The following is a description of a gene set: from publication Korkola JE, Houldsworth J, Chadalavada RS, Olshen AB, Dobrzynski D, Reuter VE, Bosl GJ, Chaganti RS (PMID 16424014) Human Gene Set: KORKOLA_SEMINOMA_UP Genes from the 12p region that were up-regulated in seminoma tumors compared to normal testis. studied in species Homo sapiens Adult male germ cell tumors (GCTs) comprise distinct groups: seminomas and nonseminomas, which include pluripotent embryonal carcinomas as well as other histologic subtypes exhibiting various stages of differentiation. Almost all GCTs show 12p gain, but the target genes have not been clearly defined. To identify 12p target genes, we examined Affymetrix (Santa Clara, CA) U133A+B microarray ( approximately 83% coverage of 12p genes) expression profiles of 17 seminomas, 84 nonseminoma GCTs, and 5 normal testis samples. Seventy-three genes on 12p were significantly overexpressed, including GLUT3 and REA (overexpressed in all GCTs) and CCND2 and FLJ22028 (overexpressed in all GCTs, except choriocarcinomas). We characterized a 200-kb gene cluster at 12p13.31 that exhibited coordinated overexpression in embryonal carcinomas and seminomas, which included the known stem cell genes NANOG, STELLA, and GDF3 and two previously uncharacterized genes. A search for other coordinately regulated genomic clusters of stem cell genes did not reveal any genomic regions similar to that at 12p13.31. Comparison of embryonal carcinoma with seminomas revealed relative overexpression of several stem cell-associated genes in embryonal carcinoma, including several core stemness genes (EBAF, TDGF1, and SOX2) and several downstream targets of WNT, NODAL, and FGF signaling (FGF4, NODAL, and ZFP42). Our results indicate that 12p gain is a functionally relevant change leading to activation of proliferation and reestablishment/maintenance of stem cell function through activation of key stem cell genes. Furthermore, the differential expression of core stem cell genes may explain the differences in pluripotency between embryonal carcinomas and seminomas., and this is the list of marker genes: AK4 (NCBI Gene Id 387851), GABARAPL1, RECQL, CD27, NOP2, KLRG1, DSTNP2, PHC1, DERA, COPS7A, ITFG2, PHB2, SINHCAF, SLC2A3, TIGAR, GAPDH, LRP6, TEAD4, GOLT1B, CCND2, VAMP1, EMG1, ARHGDIB, TULP3, PLBD1, TPI1, NDUFA9, LDHB (NCBI Gene Id 3945), FGD4, RESF1 (NCBI Gene Id 55196), TSPAN9, CREBL2, GPRC5A (NCBI Gene Id 9052), DPPA3, RHNO1, ENO2, NANOG, CD9, SPSB2, ATN1, FERRY3, GNB3, ERC1, PTPN6